Given this list of marker genes SLC11A2, SLC30A10, ATP2C2, SLC39A8, SLC11A1 (NCBI Gene Id 6556), ATP13A1, SLC41A2, TRPC7, TRPM2, TMEM165, ATP2C1, SLC39A14, here is a description of the gene set: The directed movement of manganese (Mn) ions into, out of or within a cell, or between cells, by means of some agent such as a transporter or pore. studied in species Homo sapiens Human Gene Set: GOBP_MANGANESE_ION_TRANSPORT